Given this list of marker genes Cyp4a29, Lta4h, Cyp4f18, Alox5ap (arachidonate 5-lipoxygenase activating protein), Cyp4b1, Cyp4a12b, Dpep2, Ggt5 (NCBI Gene Id 23887), Cyp4a10, Alox5, Cyp4f15, Cyp4f40, Abcc1, Cyp4a14, Cyp4f39, Cyp4f14, Ltc4s, Ggt1, Cyp4a30b, Alox15, Cyp4a32, Mapkapk2 (NCBI Gene Id 98242), Dpep1, Cyp4a12a, Cyp4a31, here is a description of the gene set: species: Mus musculus Synthesis of Leukotrienes (LT) and Eoxins (EX) Mouse Gene Set: REACTOME_SYNTHESIS_OF_LEUKOTRIENES_LT_AND_EOXINS_EX